Given this list of marker genes GAB2, STAT5A, GRB2, FLT3, STAT5B, PTPN11, FLT3LG, here is a description of the gene set: studied in species Homo sapiens STAT5 Activation Human Gene Set: REACTOME_STAT5_ACTIVATION